The following is a description of a gene set: Catalysis of the reaction: retinyl palmitate + H2O = retinol + palmitate + H+. Mouse Gene Set: GOMF_RETINYL_PALMITATE_ESTERASE_ACTIVITY studied in species Mus musculus, and this is the list of marker genes: Lipe, Ces1e, Ces2c, Ces1d, Plb1, Ces1f, Rpe65, Ces2e, Pnpla2, Pnlip, Cel, Ces2f, Ces2a